The following is a description of a gene set: Human Gene Set: GOBP_SYMBIONT_ENTRY_INTO_HOST species: Homo sapiens Entry of a symbiont into the body, tissues, or cells of a host organism as part of the symbiont life cycle. The host is defined as the larger of the organisms involved in a symbiotic interaction., and this is the list of marker genes: CTSL, P4HB, NECTIN1, PLSCR1, DYNLT1, ICAM1, TMPRSS2, CAV1, CH25H, FUCA2, HAVCR1, GYPA, NECTIN2, LGALS1, SLC3A2, WWP2, AXL, NCAM1, HYAL2, CDK1, ITGB7, SLC52A2, VAMP8, PIKFYVE, DPP4, GAS6, F11R, VPS18, CXCR4, ZNF639, LAMP3, SLC52A1, PHB1, CCR5, TRIM38, ITCH (NCBI Gene Id 83737), CLDN1, SLC20A2, HLA-DRB1, WWP1, CD55 (CD55 molecule (Cromer blood group)), INSR, EXOC7, CD80, TRIM62, UVRAG, EXOC2, TRIM25, ITGB3, EFNB3, LAMP1, ITGA5, LDLR, ITGB6, ITGB5, PVR, XPR1, MYH10, AGTR1, EPHA2, EFNB2, TYRO3, SLAMF1, SIGLEC1, SLC10A1, ANPEP, EPS15, SCARB1, TPCN2 (NCBI Gene Id 219931), CD4, NRP1, TPCN1, DAG1, CR2, CTSB, SLC1A5, ITGA2 (NCBI Gene Id 3673), KRT6A, SCARB2, CXCL8, KIAA0319L, SLC7A1, MYH9, CR1, TRIM21, SRC, CD86, CAV2, BSG, CD81, GRK2 (NCBI Gene Id 156), HMGB1, CLEC5A, RNASEK, RPSA, ACE2, KPNA3, ITGB1, ITGAV, CD46, AVPR1B, CXADR, TFRC, TRIM11, CDHR3, CLDN9, CD74, IDE, ILF3, SELPLG, GPR15, HSPA1B, TMPRSS4, NPC1, HS3ST5, FURIN, CLDN6, TNFRSF4, AVP, HSPA1A, CD209, EGFR, TNFRSF14, LGALS9, TRIM5, SERPINB3, CBL, MRC1, JPT2, SMPD1, NECTIN3, HTR2A, SIVA1, CLEC4G, CLEC4M, NECTIN4, NUP153, MOG (NCBI Gene Id 4340)